The following is a description of a gene set: studied in species Mus musculus Genes negatively differentially expressed in cell type: NK cell upon treatment with cytokine: IL-3 in mouse lymph nodes in vivo. Mouse Gene Set: CUI_NK_CELL_IL3_RESPONSE_DN from publication Cui A, Huang T, Li S, Ma A, Pérez JL, Sander C, Keskin DB, Wu CJ, Fraenkel E, Hacohen N (PMID 38057668) Cytokines mediate cell-cell communication in the immune system and represent important therapeutic targets. A myriad of studies have highlighted their central role in immune function, yet we lack a global view of the cellular responses of each immune cell type to each cytokine. To address this gap, the authors created the Immune Dictionary, a compendium of single-cell transcriptomic profiles of more than 17 immune cell types in response to each of 86 cytokines (>1,400 cytokine-cell type combinations) in mouse lymph nodes in vivo. A cytokine-centric view of the dictionary revealed that most cytokines induce highly cell-type-specific responses. For example, the inflammatory cytokine interleukin-1β induces distinct gene programmes in almost every cell type. A cell-type-centric view of the dictionary identified more than 66 cytokine-driven cellular polarization states across immune cell types, including previously uncharacterized states such as an interleukin-18-induced polyfunctional natural killer cell state., and this is the list of marker genes: Zfp36l2, Junb, Il7r, Rgs1, Fos, Jun (NCBI Gene Id 16476), Emb, Crip1, Ltb, Fosb, Tnfaip3, Xcl1 (chemokine (C motif) ligand 1), Dusp1, Hspa8